Given this list of marker genes Ehd2, Akap5, Zdhhc2, Eipr1, Actn2, Sorl1, Pla2g4e, Commd1, Ehd1, here is a description of the gene set: Mouse Gene Set: GOBP_POSITIVE_REGULATION_OF_ENDOCYTIC_RECYCLING Any process that activates or increases the frequency, rate or extent of endocytic recycling. studied in species Mus musculus